Given this list of marker genes Car13, Car10, Car14, Car4, Car8, Car11, Car15, Car2, Car3, Car9, Car5b, Car1, Car5a, Car12, Car7, Car6, here is a description of the gene set: Mouse Gene Set: GOMF_CARBONATE_DEHYDRATASE_ACTIVITY Catalysis of the reaction: hydrogencarbonate + H+ = CO2 + H2O. studied in species Mus musculus